The following is a description of a gene set: Catalysis of the hydrolysis of any non-peptide carbon-nitrogen bond in a cyclic amidine, a compound of the form R-C(=NH)-NH2. species: Mus musculus Mouse Gene Set: GOMF_HYDROLASE_ACTIVITY_ACTING_ON_CARBON_NITROGEN_BUT_NOT_PEPTIDE_BONDS_IN_CYCLIC_AMIDINES, and this is the list of marker genes: Ada, Adal, Apobec3, Adad1, Cda, Gchfr, Mthfd2l, Ampd3, Lacc1, Ampd2, Ampd1, Adarb1, Adad2, Mthfd1, Atic, Gda (NCBI Gene Id 14544), Gch1, Apobec1, Cdadc1, Adat3, Adat2, Adarb2, Mthfd2, Pycr3, Adar, Dctd, Adat1, Aicda, Apobec2